The following is a description of a gene set: Genes negatively differentially expressed in cell type: NK cell upon treatment with cytokine: IL-15 in mouse lymph nodes in vivo. Cytokines mediate cell-cell communication in the immune system and represent important therapeutic targets. A myriad of studies have highlighted their central role in immune function, yet we lack a global view of the cellular responses of each immune cell type to each cytokine. To address this gap, the authors created the Immune Dictionary, a compendium of single-cell transcriptomic profiles of more than 17 immune cell types in response to each of 86 cytokines (>1,400 cytokine-cell type combinations) in mouse lymph nodes in vivo. A cytokine-centric view of the dictionary revealed that most cytokines induce highly cell-type-specific responses. For example, the inflammatory cytokine interleukin-1β induces distinct gene programmes in almost every cell type. A cell-type-centric view of the dictionary identified more than 66 cytokine-driven cellular polarization states across immune cell types, including previously uncharacterized states such as an interleukin-18-induced polyfunctional natural killer cell state. from publication Cui A, Huang T, Li S, Ma A, Pérez JL, Sander C, Keskin DB, Wu CJ, Fraenkel E, Hacohen N (PMID 38057668) Mouse Gene Set: CUI_NK_CELL_IL15_RESPONSE_DN studied in species Mus musculus, and this is the list of marker genes: Add1, Gigyf1, Lamtor2, Dgkz, Selplg, Cdkn2d, Gprin3, Rsrp1, Arhgef18, Cnn2, Npc2, As3mt, Thap3, Commd8, Luc7l2, Klf2, Arhgap15, Pglyrp1, Pfdn5, Arrb2, Gnai2, Abcg1, Qrfp, Gpsm3, Dap, Dock2, Rac2, Anxa1, Saraf, Emp3, Sorl1, Arl4d, Plgrkt, Arhgap45 (Rho GTPase activating protein 45), Tspan32, H2-Q7, Eef1a1, Klf6, Ctla2a, Tsc22d4, Fos (FBJ osteosarcoma oncogene), Eif3f (NCBI Gene Id 66085), Tsc22d3, Ccr2, Rabgap1l, Rnaset2b, Pdcd4 (NCBI Gene Id 28204), Cd7, Arhgap18, Cd37, Pnisr, Btg2, Surf1, Lat2, Arsb, Dcxr, Cd28, Ctsd, Adcy7, Myl12b, Serinc3, Lsp1, Itgb1, Ogt, R3hdm4, Cox20, Cited4, AB124611, Cox7a2l, Dguok, Zeb2, Tmem59, Agtrap, H2-D1, Heca, Rnf166, Smpdl3a, Gas7, Zfp945, Ppp1r12a, Rnf130, St3gal6 (ST3 beta-galactoside alpha-2,3-sialyltransferase 6), Elk3 (ELK3, member of ETS oncogene family), Ostf1, Samd3, Fth1, Tbc1d10c (TBC1 domain family, member 10c), Foxn3, Lck, Spry2, Tcf7, Septin1, Cuta, Crybg1 (crystallin beta-gamma domain containing 1), Fosb, Crip1, H2-Q6, H1f2, Cd44, Zfp36l2, Il18r1, Txnip, Gpx4, Git2, Selenop, Arhgdib, Bin2, Akap13, Rp9, Cd96, Sh3kbp1, Cdk2ap2 (cyclin dependent kinase 2 associated protein 2), Tnrc6b, Cnot6l, Kif21b, Plec, Zfp36, Tmsb10, Scamp3, Sla, Hmgb2, Sytl2, Irf2bpl, Cxcr3, Hmgb1, Calm2, Lbh, Fau, 9930111J21Rik2, Dgka, Tle5, Epsti1, Psap, Smad7, Neat1, Ripor2, Twf2, Stk10, Srpk2, Peli1, Ptpn18, Hmgn5, Klf3, Cdc42ep3, Stard10, Itgb7, H2az1, Nlrc3, Fcgr3, Ucp2, Scand1, Ablim1, Trp53inp1, Itgam, Ncoa2, Ets1, Atp5pd, Bcl9l, Fam53b, Mapre2, Ccl5, Il7r, Jun, Pitpnc1, Ing1, Myo1f, Vamp8, Capn1, Maf1, Uqcrh, Laptm5, Cxcr4, Ppp1r9b, Psmb9, Atp1b1, Klf13, Klrd1, Pycard (PYD and CARD domain containing), Cirbp, Glmp, Wrn, Limd2, Malt1 (MALT1 paracaspase), Ppil2, Neurl3, Fryl, Gmfg, Arhgef2, H2az2, Stim1, Numa1, Crebrf, Nr3c1, Rabac1, Pbxip1, Rhob, Itpr2, Clic1, Vim, Itm2a, Nptn, Sh3bgrl3, Sri, H2-K1, Klrc2, Mrtfa, Klhl24, Tmem71, Tyrobp, Cd27, Trim12a, Antkmt, Tmem50a, Rnf167, Jak1, Hint2, Paip2, Itgax, Gata3, Prkacb, Shisa5, B4galt1, S100a11, AI467606, Tecpr1, Sike1, Ctdsp2, Acaa1a, Syf2, Gabarap, Tm6sf1 (NCBI Gene Id 83487), Zbtb20, Slc12a6, Tut4, Tmem234, Zfp36l1, Ppp3ca, Phf1, Iqgap1, Zbtb4, Ighm, Jakmip1, Acaa2, Hsd11b1, Cd2, Mxd4, Ltb (lymphotoxin B), Ctsw, Ech1, Ssbp2, Hspa1b, Smarca2, Clk1, Sipa1, Ubc, Otulinl, Pnrc1, Prkcb, Ubr2, Tespa1, Pold4, Cd9, Atp2a3 (ATPase, Ca++ transporting, ubiquitous), Tspo, Dapk2, Emb, Card19, Fuca1, Hspa1a, S100a10, Tnik, Dusp1, Ptprcap, Septin6 (septin 6), Smim14, Ahnak, Uba52, Ndufa6, Lppos, Rbm39, Crot, Entrep3, Arl5c, Sat1, St8sia4, Celf2, Bscl2, Kmt2c, Gnb2, Utrn, Mbnl1, Rgs2, Pigp, Atf7ip, Sntb2, Bnip3l, Add3, Itm2c, Ypel3, Klrk1, Sp100, Itm2b, Il18rap, Zyx, Prr13, Cbl, Mef2a, Pdgfb, Arhgef1, Rbpms, Macf1, Kmt2e, Btg1, Sptbn1, Hcst, Pitpnm1, Evl, Cd84, Cd72, Esyt2, Dhrs7